The following is a description of a gene set: species: Mus musculus Mouse Gene Set: GOBP_CARDIAC_ENDOTHELIAL_CELL_DIFFERENTIATION The process in which a relatively unspecialized cell acquires the specialized structural and/or functional features of a cardiac endothelial cell., and this is the list of marker genes: Nrg1, Pbrm1 (polybromo 1), Sox17, Acvr1, Notch1, Prok2, Sox18, Smad4